Given this list of marker genes ACACB, ACADVL, SIRT4, FMO2, DGAT2, APPL2, ACADL, SOX9, ETFBKMT, PLIN5, MFSD2A, AKT1, FMO4, FMO1, here is a description of the gene set: Any process that stops, prevents, or reduces the frequency, rate or extent of fatty acid oxidation. species: Homo sapiens Human Gene Set: GOBP_NEGATIVE_REGULATION_OF_FATTY_ACID_OXIDATION